The following is a description of a gene set: Human Gene Set: WP_WNT_SIGNALING_NETPATH Wnt signaling, NetPath studied in species Homo sapiens, and this is the list of marker genes: DVL1, MAPK8, PRKCG, DVL2, LRP5, AXIN2, MAP3K7, RYK, ARRB2, GSK3A, DVL3, TCF7L2, TSC2, RHOA (NCBI Gene Id 387), LEF1, BCL9, MYC, AKT1, FRAT1, MAPK1, CSNK1E, CDK6, CSNK1A1, NFATC2, PRKCA, TCF3, PPARG, PI4K2A (phosphatidylinositol 4-kinase type 2 alpha), PIP5K1B, GJA1, APC, GCKR, SOX1, ROR1 (receptor tyrosine kinase like orphan receptor 1), MTOR, TEK, TSC1, CTNNB1, LRP6, CSNK1G1, CCND1, GSK3B, PRKCB, CSNK1D, TCF4, MAPK9, NLK, AXIN1, RAC1, ROR2, CTBP1